Given this list of marker genes Mafb, Col6a1, Ubxn2a, Chmp6, Chmp2a, Pex11a, Psap, Pex16, Nlgn2, Flot1, Anxa2, Clec2i, Emp2 (NCBI Gene Id 223964), Chmp2b, Vps4a, Spast, Pex3 (peroxisomal biogenesis factor 3), Reep4, Il1rapl1, Stx4a, Chmp4b, Chmp5, Chmp1b2, Iqgap1, Ephb2, Clip3, Tlcd2, Dmkn, Ankle2 (NCBI Gene Id 71782), Ubxn2b, Chmp1a, Chmp4c, Tlcd1, Ugcg, Rftn1, Exoc4, Ptprd, Brox, Nlgn4l, Cav1, Nrxn2, Magi2, Stx2 (NCBI Gene Id 269706), Pex19, Selenon, Josd1, Nsfl1c, Reep3, Lrp4, Chmp1b, Hdac3, Chmp3, Cav3, Banf1, Zfp750, Pten, Nrxn1, Chmp7, Vps4b, Serinc1, Cdh2, Cav2, Sptbn1, Lrch4, Nlgn3, Ank3, Ilk, Pacsin2, S100a10, Nlgn1, here is a description of the gene set: Mouse Gene Set: GOBP_MEMBRANE_BIOGENESIS A cellular process that results in the biosynthesis of constituent macromolecules, assembly, and arrangement of constituent parts of a membrane. species: Mus musculus